Given this list of marker genes JADE1, EOMES, ZIC3, ZNF254 (NCBI Gene Id 9534), RAB6A (NCBI Gene Id 5870), IQGAP2, ZFHX3, SOD3, PACRG, PLEC (NCBI Gene Id 5339), SAMD13, GEMIN2, ADGRF3, UBN1, CD226, PRKAR2B, YOD1, GJB7, EPHA4, ECHDC1, PHTF2, CAMK1D, CSGALNACT2, EPHB1, ARHGAP28 (NCBI Gene Id 79822), FMNL2, NR4A3, ZNF561, DPP10, KLF5, PEAK1, TCP1, PDCD2, IPO5, ABHD10, FNBP4, FOXN2, STAR, SATB1, IBTK, NEUROD1 (neuronal differentiation 1), GRID2, KRTAP6-3, PDE1A, KMT5B, EFR3A, CLEC4E, NAV1, MPZ, TNFSF13B, OGFOD1, SOX21, RSRC1, ESRRG, UNC5C, SAMD9, PAQR3, TENM1, SLC6A14, here is a description of the gene set: Genes predicted to be targets of miRBase v22 microRNA hsa-miR-219b-3p in miRDB v6.0 with MirTarget v4 prediction scores > 80 (high confidence targets). species: Homo sapiens from publication Chen Y, Wang X (PMID 31504780) Human Gene Set: MIR219B_3P